The following is a description of a gene set: species: Mus musculus Mouse Gene Set: GOCC_SORTING_ENDOSOME A multivesicular body surrounded by and connected with multiple tubular compartments with associated vesicles., and this is the list of marker genes: Nrp1, Ptpn1, Arhgap1, Kdr, Ldlr